The following is a description of a gene set: Mouse Gene Set: GOBP_REGULATION_OF_TRANSLATIONAL_INITIATION_BY_EIF2_ALPHA_PHOSPHORYLATION studied in species Mus musculus Any process that modulates the frequency, rate or extent of translation initiation in response to stress by the phosphorylation of eIF2 alpha., and this is the list of marker genes: Eif2ak3, Eif2ak1, Nck1, Fech, Eif2ak4, Hbb-bs, Npm1, Dnajc3, Tmed2